The following is a description of a gene set: NGF-stimulated transcription studied in species Homo sapiens Human Gene Set: REACTOME_NGF_STIMULATED_TRANSCRIPTION, and this is the list of marker genes: VGF, ATF2, CDK5, FOS, TRIB1, SRF, FOSB, EGR2, ID4, CHD4, SGK1, ARC, F3, TCF12, SH3GL3, EP300, REST, ATF1, ID3, NAB1, CDK5R2, RRAD, FOSL1, ELK1, EGR1, EGR4, TPH1, ID2, LYL1, CREB1, JUND, DNM2, ID1, ASCL1 (achaete-scute family bHLH transcription factor 1), CDK5R1, NAB2, MEF2D, EGR3, JUNB